The following is a description of a gene set: Human Gene Set: HP_CONFUSIONAL_AROUSAL Confusional arousal species: Homo sapiens A nocturnal episode is characterized by disorientation, grogginess, and, at times, significant agitation upon awakening from slow-wave sleep or following forced awakenings., and this is the list of marker genes: DEPDC5, KCNT1, SIM1, CHRNB2, CABP4, CHRNA4, CHRNA2, CRH, MAGEL2